The following is a description of a gene set: Human Gene Set: HP_BIFID_RIBS Bifid ribs A bifid rib refers to cleavage of the sternal end of a rib, usually unilateral. Bifid ribs are usually asymptomatic, and are often discovered incidentally by chest x-ray. species: Homo sapiens, and this is the list of marker genes: PTCH2, CASZ1, MMP23B, UBE4B, PTCH1, PRDM16, RERE, HSPG2, TMCO1, SPEN, PDPN, GABRD, PRKCZ, SKI, KCNAB2, LUZP1, SUFU